The following is a description of a gene set: Genes having at least one occurrence of the highly conserved motif M81 CGGAARNGGCNG in the regions spanning 4 kb centered on their transcription starting sites. The motif does not match any known transcription factor binding site. Comprehensive identification of all functional elements encoded in the human genome is a fundamental need in biomedical research. Here, we present a comparative analysis of the human, mouse, rat and dog genomes to create a systematic catalogue of common regulatory motifs in promoters and 3' untranslated regions (3' UTRs). The promoter analysis yields 174 candidate motifs, including most previously known transcription-factor binding sites and 105 new motifs. The 3'-UTR analysis yields 106 motifs likely to be involved in post-transcriptional regulation. Nearly one-half are associated with microRNAs (miRNAs), leading to the discovery of many new miRNA genes and their likely target genes. Our results suggest that previous estimates of the number of human miRNA genes were low, and that miRNAs regulate at least 20% of human genes. The overall results provide a systematic view of gene regulation in the human, which will be refined as additional mammalian genomes become available. studied in species Homo sapiens from publication Xie X, Lu J, Kulbokas EJ, Golub TR, Mootha V, Lindblad-Toh K, Lander ES, Kellis M (PMID 15735639) Human Gene Set: CGGAARNGGCNG_UNKNOWN, and this is the list of marker genes: ADAMTSL5, CCDC6, CUTA, RGL2, CHCHD5, WWP2, UMPS, PCGF1 (polycomb group ring finger 1), LMAN2, C1orf74, TMEM30A (transmembrane protein 30A), DUSP6, DCAF10, EML2, TAF9, UBE2F, IRAK1, PANK2, RHOBTB2, CCDC171, POLH, CLTC, LINC01089, RAD17, HNRNPH1, TP53, RNF14, GTF2A1, CTR9, RAB4B, PAX2, IGF2BP2, GCA, MARCHF6, SLC36A1, FEZF2, EGR1, TMEM187, CFL1, GLYR1, KAT5, PTGES3, VPS39, ATP2A2, URM1, UBXN8, BIN3, SPTLC2, TXNDC12, C19orf53, GANAB, CHMP2A, TMED2, TPT1, XPO5, CDC37